Given this list of marker genes SLC18A3, SNAP25, RTTN, RPL10, SELENON, MYH7, PIGN, PAX1, POLR1D, IPO8, SCO2, CEP55, PUF60, ALG13, TASP1, EIF4A3, RELN, GMNN, CANT1, ORC6, CTCF, BANF1, OCLN, KATNB1, AGRN, DHCR7, KIF7, ZC4H2, CREB3L1, SYT2, SIN3A, GLDN, TELO2, TMEM70, WDR11, CHAT, SF3B4, FBXL3, ESAM, CSGALNACT1, TXNDC15, CRIPT, ALG9, OFD1, GAD1, C2CD3, SLC25A1, TUBA1A, INTS1, NAA10 (NCBI Gene Id 8260), LMNA, VAMP1, NSMCE2, YARS1, TTN, PRORP, CEP120, CHST3, NEDD4L, SEC24D, PRDM13, COL13A1, KPTN, B3GAT3, KAT6A, CTNND2, GLI3, CHST14, NDE1, MYO9A, KCNK9, NFIX, BMP4, SLC5A7 (solute carrier family 5 member 7), COL2A1, TAF1, SLC35A3, TRIP4, SLC10A7, EBP, DSE, RSPO2, NSDHL, ATP6V0A2, SEMA5A, here is a description of the gene set: Microretrognathia species: Homo sapiens A form of developmental hypoplasia of the mandible in which the mandible is mislocalised posteriorly. Human Gene Set: HP_MICRORETROGNATHIA